The following is a description of a gene set: studied in species Homo sapiens Genes having at least one occurrence of the motif NNCATNSRWAATNMRN in the regions spanning 4 kb centered on their transcription starting sites. This matches the POU3F2 transcription factor binding site V$BRN2_01 (v7.4 TRANSFAC). Human Gene Set: BRN2_01, and this is the list of marker genes: DUSP10, PTPRCAP, SGK3, CACNA1C, SULF1 (NCBI Gene Id 23213), NAT8L, ELMO1, MSI2, ETV4, SLC26A7, PIK3CG, LINC00670, DNAI1, BAMBI, C5, ERG, PLEC, KLF12, KCNQ1DN, ITK, ANLN, CUX1, CS, PTHLH, MYF5, ETV5, BCOR, TENM1, MTMR11, ANKS1B, BCL11A, ESRRG, RHOJ, MARCHF1 (membrane associated ring-CH-type finger 1), IP6K2, NDST3 (NCBI Gene Id 9348), SMOC2, ARHGEF12, CIB3, UBA1, MDM1, HOXC11, TCF4, FGF14, NR2E1, GARRE1, SNAP25, PPM1B, STMN2, NRAS, NFIA, MGAT4C, GDNF, SHH, N6AMT1, RPE65, PATL1, INPPL1, HOXA10, VAX1, NRSN1, COL12A1, STEAP2, AOC2, HOOK1, GPR3, CARMIL3, GNAO1, CHN2, KCNMB2, RHEBL1, NFATC4, FAM53B, MBNL1, PPP1R1B, TXN, LRGUK, CTNNA1, MYO1B, RAB8B, FOXP2, TEF, ST8SIA3, PHLDA2, ACSM3, RGS6, FGFR2, PDZRN4, ADPGK, ZNF385B, ANGPT1, ASB11, H3-3B, BCL9, HS3ST5, POLR3B, CCND1, FOSL1, IMPDH2, MECOM, CNBD1, HOXB9, FLRT3, AAK1, OSBPL7, MBNL2, DUSP6, ADCYAP1, VAMP3, SIPA1, IQGAP3, TACC2, ABCB5, TAC3, EDNRA, TENT5D, CLOCK, NFAT5, IMMT, LAMA4, REXO4, NR3C2, MYH2, SLCO3A1, TUFT1, CNN3, IL18RAP, UBL3 (NCBI Gene Id 5412), PTCHD4, ITGB3BP (integrin subunit beta 3 binding protein), NTF3, SAYSD1, SAT1, FOS, FGF10, ASIC2, NDUFB8, TSPAN13, ENOX2, RPE, ASCL4, SLIT3, PTPRO, UNC13D, DNAH8, TOB1, PPP1R16B, KRTAP13-2, SPRY4, CHMP2A, CPNE1, SLITRK1, NCAM2, TRIAP1, FGF13, FAM219A, ZBTB9, IGF2BP3, PHF3, PTPRG, PCF11, HOXD4, SNTB2, DLX1, PDGFC (platelet derived growth factor C), SOX3, CASC2, GLRA2, NEUROG1 (neurogenin 1), PLCB2, PPP4R3C, INTS12, CHD6, EAF1, NRXN3, CBFB, ADAM11, IRX4, CTNNBIP1, GPM6A, MGLL, FRMD6, CDKL5, YRDC, PIM1, HOXC4, GSTCD, HOXB3, NOG, PHOX2B, ELL, NT5C1B (5'-nucleotidase, cytosolic IB), PRICKLE2, ZMIZ1, PRPF19, TAFAZZIN, USP32, TLCD5, CADM1, CLEC4A, CDIN1, TP63, HIVEP1, CSRNP3, DCX, NPAS2, SALL1, MYT1, EYA1, VGLL1, BAZ1A, DIABLO, MYO18A, ARF6, C1orf122, EHD4, SALL3, CTNND2, PCDH18, PRKAG1, TPH2, MYO3B, CREB5, STX11, CBL, FOXG1, EIF4A1, EXTL2, RIT1, DMD, FGFR3, LIN54 (NCBI Gene Id 132660), SLC6A4, NR4A3, MMP16 (matrix metallopeptidase 16), GPX1, BTBD10 (NCBI Gene Id 84280), ALKBH8, AIFM1, AGTPBP1